The following is a description of a gene set: studied in species Mus musculus Mouse Gene Set: GOMF_COLLAGEN_V_BINDING Binding to a type V collagen trimer., and this is the list of marker genes: 2300002M23Rik, Hspg2, Gpc1, Ecm2, Thbs1